The following is a description of a gene set: Skeletal-type VGCC-RYR signaling. Pathway ID: N01638. Pathway type: Reference. Pathway class: nt06528 Calcium signaling. Human Gene Set: KEGG_MEDICUS_REFERENCE_SKELETAL_TYPE_VGCC_RYR_SIGNALING species: Homo sapiens Pathway Definition from KEGG: CAV1.1 -> (RYR1+TRDN+JCN+CASQ) -> Ca2+(cyto), and this is the list of marker genes: CACNA2D4, ASPH, TRDN, CACNA2D2, RYR1, CACNB1, CACNB2, CACNG5, CACNG3, CASQ2 (NCBI Gene Id 845), CACNG6, CACNA1S, CACNG1, CACNA2D3, CASQ1, CACNG4, CACNB4, CACNG7, CACNB3, CACNG2, CACNA2D1